The following is a description of a gene set: species: Mus musculus Mouse Gene Set: GOCC_CIS_GOLGI_NETWORK_MEMBRANE The lipid bilayer surrounding any of the compartments that make up the cis-Golgi network., and this is the list of marker genes: H2-M10.6, Trappc3, Rab18 (NCBI Gene Id 19330), H2-Q2, H2-Q10, Gpr108, H2-T22, Tmem165, H2-M5, H2-Q7, Rnf183 (NCBI Gene Id 76072), H2-M10.2, H2-M11, H2-M10.4, Pmel, H2-Q1, Phtf1, Vps13b, H2-M10.1, Bok, Trappc3l, H2-M2, H2-K1 (NCBI Gene Id 56628), Atp2c1, H2-D1, H2-Q6 (NCBI Gene Id 636948), H2-M3